Given this list of marker genes PHC3, BCL6, ICAM5, CEACAM1, LRP3, MSRB2, COLEC12, TGS1, CDIPT, ZNF239, CBX5, SPRED3 (sprouty related EVH1 domain containing 3), PPP1R1B, SLC26A7, SLC41A1, MLX, OST4, SEC14L5, ZNF124, BLID, PYGO2, TBC1D7, ATRNL1, IL6ST, TMEM81, NDUFAF3, CNOT6, ETNK2, PHF20, TEP1, AASS, APOOL, RESF1, SLC23A2, ITPRID1, ZBTB22, GPD1, TMC1, SMARCA2, RBMX, ZNF287, CHD9, SLC38A4, ARHGEF28, NUP93, LUC7L3, BTG2, ULBP1, SPPL2C, PCLAF (NCBI Gene Id 9768, PCNA clamp associated factor), MYO10, FURIN, FHDC1, ARL5A (ADP ribosylation factor like GTPase 5A), KCNIP2, KIF3C, FAM78A, CDKL4, CD86, ZNF875, TRMT10A, LILRA1, WDR48, PFDN2, YAE1, PTAR1, RSBN1, ANAPC10, TMEM144, MTUS2, EPHA5, here is a description of the gene set: from publication Chen Y, Wang X (PMID 31504780) studied in species Homo sapiens Human Gene Set: MIR3132 Genes predicted to be targets of miRBase v22 microRNA hsa-miR-3132 in miRDB v6.0 with MirTarget v4 prediction scores > 80 (high confidence targets).